Given this list of marker genes CNGA1, KDM5B (NCBI Gene Id 10765), METTL8, RALGPS2 (Ral GEF with PH domain and SH3 binding motif 2), MIR302D, QSER1, SERPINC1, IZUMO1R, TRPM1 (NCBI Gene Id 4308), ACTN2, RNF167, SYNE1, LRRC1, PLCB2, PDK1, CARD6, ANGPTL1, LDLRAP1, IGFBP4, KIZ (NCBI Gene Id 57166), SLC39A2, MAP3K12, TDRKH, MBD5, CHST15 (NCBI Gene Id 9916), RNF122, FAM78A, MTSS1, USP28, SLC43A2, RNF32, ADGRL1, CCR7, AMPD1, RAB6B, ST8SIA1, NLK, HSD17B8, MGRN1, C7, DAPL1, HECTD2, OVGP1, HSPBAP1, USP24, ZMAT1 (NCBI Gene Id 84460), BACH2, TET3, PRRG1, ABCA1, ALS2CL, HDAC7, MBP, SNX29, SLC17A9, KLF3, IGF1R, FOXJ2, NSG2, CHCHD7, ZNRF1, NEDD4L, AFP, CCND2, NSD3, LDHB, SSBP2, ACVR2A, FOXP1, TIMP2, AKAP5, TCF20, PNPLA7, AGL, KIF1B, CREBL2, ST6GAL1, PLEKHA1, CD55, WDR13, NTRK3, TANC1, KLHDC1, KAT6B, NPFF, RFLNB, OLFML3, EML5, SELL, DZIP1, SPACA1, S100G, MYC, RERE, ZBTB20, IL6R, CYTH3, BCORL1, TGFBR3, SELENOP, ADGRL2, EVL, GRIA3, IKBKE, JAKMIP1, SLC25A27, LRRC23 (leucine rich repeat containing 23), RASGRP1 (RAS guanyl releasing protein 1), RAPGEF4, TCF7, KBTBD11, ZNRF3, SLC49A4, VIPR1, SLC16A5, FNTB, LRP6, TRAT1, PPP1R13B, CCR9, ART4, SUN2, LRATD2, TREML2, TMEM185B, SH3BP5, MPPE1, TOM1L2, SELE, PLEKHG2, LEF1, TET1, APPL2, SCML4, ADGRG5, CD72, TTC28, BCOR, RPL19, ZHX2, CRIPTO, DDC, EPHX1, PHF21A, ACSS1, MAML2, ARL5C, TECPR1, XKRX, TTC3, PKD1, WLS, SIDT1, PATJ, CEP68, ABTB3, LRIG1, ITGAE, FBXL12, ANGEL1, RAB3IP, FOXO1, here is a description of the gene set: Genes down-regulated in B lymphocytes: ZFX knockout versus wildtype cells stimulated by anti-IgM for 12h. The development, homeostasis and function of B lymphocytes involve multiple rounds of B cell receptor (BCR)-controlled proliferation and prolonged maintenance. We analyzed the role of transcription factor Zfx, a recently identified regulator of stem cell maintenance, in B cell development and homeostasis. Conditional Zfx deletion in the bone marrow blocked B cell development at the pre-BCR selection checkpoint. Zfx deficiency in peripheral B cells caused impaired generation of the B-1 cell lineage, accelerated B cell turnover, depletion of mature recirculating cells, and delayed T-dependent antibody responses. Zfx-deficient B cells showed normal proximal BCR signaling, but impaired BCR-induced proliferation and survival. This was accompanied by aberrantly enhanced and prolonged integrated stress response, and delayed induction of Cyclin D2 and Bcl-xL proteins. Thus, Zfx restrains the stress response and couples antigen receptor signaling to B cell expansion and maintenance during development and peripheral homeostasis. from publication Arenzana TL, Smith-Raska MR, Reizis B (PMID 19329779) Human Gene Set: GSE13547_CTRL_VS_ANTI_IGM_STIM_ZFX_KO_BCELL_12H_DN species: Homo sapiens